Given this list of marker genes Scn10a, Scn5a, Cacna2d1, Kcna5, Trpm4, Rangrf, Gja5, here is a description of the gene set: Any process that mediates the transfer of information from a bundle of His cardiomyocyte to a Purkinje myocyte. studied in species Mus musculus Mouse Gene Set: GOBP_BUNDLE_OF_HIS_CELL_TO_PURKINJE_MYOCYTE_SIGNALING